The following is a description of a gene set: The ternary complex factor Net/Elk3 is downregulated in hypoxia and participates in the induction by hypoxia of several genes, including c-fos, vascular endothelial growth factor and egr-1. However, the global role of Net in hypoxia remains to be elucidated. We have identified, in a large-scale analysis of RNA expression using microarrays, more than genes that are regulated by Net in hypoxia. In order to gain insights into the role of Net in hypoxia, we have analysed in parallel the genes regulated by HIF-1alpha, the classical factor involved in the response to hypoxia. We identified about genes that are regulated by HIF-1alpha in hypoxia. Surprisingly, when we compare the genes induced by hypoxia that require either Net or HIF-1alpha, the majority are the same (75%), suggesting that the functions of both factors are closely linked. Interestingly, in hypoxia, Net regulates the expression of several genes known to control HIF-1alpha stability, including PHD2, PHD3 and Siah2, suggesting that Net regulates the stability of HIF-1alpha. We found that inhibition of Net by RNAi leads to decreased HIF-1alpha expression at the protein level in hypoxia. These results indicate that Net participates in the transcriptional response to hypoxia by regulation of HIF-1alpha protein stability. Genes up-regulated in SEND cells (skin endothelium) at normal oxygen (normoxia) conditions after knockdown of HIF1A by RNAi. Mouse Gene Set: GROSS_HIF1A_TARGETS_UP from publication Gross C, Dubois-Pot H, Wasylyk B (PMID 17704799) studied in species Mus musculus, and this is the list of marker genes: Ddr2, Tcf7l1 (transcription factor 7 like 1 (T cell specific, HMG box)), C3, F2r, Mafb, Tlr2, Xntrpc, Mro